The following is a description of a gene set: Reactome Pathway: Organelle biogenesis and maintenance This event has been computationally inferred from an event that has been demonstrated in another species.<p>The inference is based on the homology mapping from PANTHER. Briefly, reactions for which all involved PhysicalEntities (in input, output and catalyst) have a mapped orthologue/paralogue (for complexes at least 75% of components must have a mapping) are inferred to the other species. electronically inferred by orthology from the curated human pathway species: Mus musculus, and this is the list of marker genes: Atp5mk, Ttc8, Rp2, Wdr35, Actr1a, Cluap1, Prkaca, Ttc21b, Cep72, Ift80, Tuba1a, Ift70a1 (intraflagellar transport 70A1), Cct5, Dynlt2a2, Bbs10, Idh2, Cep131, Ift81, Ift22, Atp5po, Prkar2b, Ift88, C2cd3, Rab8a (RAB8A, member RAS oncogene family), Rab11a, Atp5f1b, Bbs2, Tuba4a, Kifap3, Exoc1, Sod2, Tuba1b, Exoc2 (NCBI Gene Id 66482), Dctn1, Sstr3, Mchr1, Cep135 (centrosomal protein 135), mt-Atp8, Haus7, Cep63, Cngb1, Cnga4, Ift70b, Haus5, Haus8, Tuba3b, Inpp5e, Gabpa, Ywhae, Ift172, Dynlrb2, Atp5pd, Bbs7, Sdccag8, Ninl, Kif3c, Cep83, Cct8, Bbs1, Dynlt2a3, Dynlt5, Rho, Cct2, Tubb6, Atp5pf, Cep152, Atp5mc2, Lztfl1, Tubal3, Sfi1, Ift57, Ift25, Plk1, Nde1, Dynll1, Clasp1, Ift74, Tctn2, Tuba1c, Gabpb1, Cycs, B9d2, Mks1, Smo, Cdk1, Cct3, Nphp1, Ift27, Cep41, Rab3ip, Cep43, Glud1, Dync2i2, Arl3, Dync2i1, Nedd1, Tubb2b, Tctn3, Cep89 (NCBI Gene Id 72140), Atp5mc1, Tubb4a, Nphp3, Cep290, Dmac2l, B9d1, Asap1, Cenpj, Sirt4, Tubb4b, Atat1, Haus1, Tuba8, Csnk1e, Cep192, Exoc7, Cep57